Given this list of marker genes STAT3, SIX1, CFLAR, MSTN, ANGPT1, EPHB1, SIX5, PPARD, MYOG (myogenin), FGF2, AKIRIN1, JAK2, PAXBP1, here is a description of the gene set: species: Homo sapiens Any process that modulates the frequency, rate or extent of skeletal muscle satellite cell proliferation. Human Gene Set: GOBP_REGULATION_OF_SKELETAL_MUSCLE_SATELLITE_CELL_PROLIFERATION